The following is a description of a gene set: Mouse Gene Set: GOBP_NEGATIVE_REGULATION_OF_INTERLEUKIN_4_PRODUCTION Any process that stops, prevents, or reduces the frequency, rate, or extent of interleukin-4 production. species: Mus musculus, and this is the list of marker genes: Ddit3, Lef1, Cd83, Scgb1a1, Mir301, Zfpm1, Foxp3 (NCBI Gene Id 20371), Ndfip1